Given this list of marker genes Gata6, Numa1, Kdr, Neo1, Kcp, Notch1, Foxd1, Vsir, Ilk, Gata4, Twsg1, Hes1, Rbpj, Smad2, Ccn1, Ube2o, Crb2, Zfp423, Bmp4, Sulf1, Elapor2 (NCBI Gene Id 231014), Fbxl15, Pelo, Gdf5, Ngly1, Msx2, Tgfbr3, Msx1, Sox11, Cdh5, Hes5, Fkbp8 (FK506 binding protein 8), Tbx20, Gdf2, Acvrl1, Ark2c, Notch2, Gpc3, Eng, Scube3, here is a description of the gene set: studied in species Mus musculus Mouse Gene Set: GOBP_POSITIVE_REGULATION_OF_BMP_SIGNALING_PATHWAY Any process that activates or increases the frequency, rate or extent of BMP signaling pathway activity.